The following is a description of a gene set: An RNA interference pathway in which microRNAs (miRNAs) block the translation of target mRNAs into proteins. Once incorporated into a RNA-induced silencing complex (RISC), a miRNA will typically mediate repression of translation if the miRNA imperfectly base-pairs with the 3' untranslated regions of target mRNAs. Human Gene Set: GOBP_MIRNA_MEDIATED_GENE_SILENCING_BY_INHIBITION_OF_TRANSLATION species: Homo sapiens, and this is the list of marker genes: MIR100, MIR200C, MIR128-1, MIR145, MIR106B, LIMD1, AGO3, EIF4ENIF1 (NCBI Gene Id 56478), MIR135B, MIR181D, MIR210, MIR96, MIR874, MIR21, MIR200B, MIR103A1, MIR520C, MIR19B1, MIR6086, MIR146A, AJUBA, MIR144, AGO2, MIR205 (microRNA 205), MIR181C, MIR17, DDX6, MIR9-1, EIF6, MIRLET7A1, MIR10B, TRIM71, MIR204, ZFP36, MIR29A, MIR98, MIR27B, MIR31, MIR346, MIR499A, MIR221, MIR26B, MIR365A, MIR27A, MIRLET7I, MIR20A, MIR299, MIR659, MIR181B1, TNRC6C (trinucleotide repeat containing adaptor 6C), MIR125A, MIR503, TNRC6A, MIR148A, MIR141, AGO1, MIR877, MIR138-1, MIR212, MIR15B, MIR125B1, EIF4E2, TNRC6B, MIR15A, MIR181A2, MIR483, MIR520B, MIR939, MIR24-1, MIR126, EIF4G1, MIR495, AGO4, MIR208A, MIR345, MIR107, MIR133B, MIR132, RBM4, MIR101-1, MIR182, WTIP, MIR16-1, MIR1-1, MIR214, MIR134, MIR520E, MIR590, MIR148B, MIR29C, MIR379 (microRNA 379), MIR1271, MIR106A, MIR218-1 (NCBI Gene Id 407000), MIR378A, MIR92A1, MIR29B1, MIR298, MIR28